The following is a description of a gene set: TCA cycle (aka Krebs or citric acid cycle) Human Gene Set: WP_TCA_CYCLE_AKA_KREBS_OR_CITRIC_ACID_CYCLE species: Homo sapiens, and this is the list of marker genes: SDHA, MDH2, DLST (dihydrolipoamide S-succinyltransferase), IDH3G, IDH3B, FH, DLD, IDH3A, SUCLA2, CS, SDHC (succinate dehydrogenase complex subunit C), SUCLG1, OGDH, SUCLG2, IDH2, ACO2, SDHB (NCBI Gene Id 96200), SDHD